Given this list of marker genes Apex1, Plac8, Stard3nl, Strap, Mybbp1a, Npm1, Tmem147, Ak2, Gnl3, Ppa1, Slc25a39, Ybx1 (Y box protein 1), Cdk2ap1, Uqcc4, Eif4a1 (NCBI Gene Id 13681), Cct3, Il4ra, Pdcd4, Lsm4, Eno1 (NCBI Gene Id 269605), Mettl1, Ppp3cc, Uqcc2, Hnrnpu, Elf1, Fabp5, Mia2, Eif5a, Hnrnpdl, Nolc1, Tpi1 (triosephosphate isomerase 1), Serbp1, Mif, Adh5, Trgc4, Farsa, Slc25a5 (NCBI Gene Id 11740), Dock10, Impact, Pa2g4, Wdr18 (NCBI Gene Id 76447), Hsp90ab1, Hmgb1, Mrps28, Chrac1, Supt16, Ydjc, Nme1, Mrpl36, Gzma, Denr, Snrpf, Nsun2, Lsm7, Nptn, Mrpl12, Tkt, Ptma, Fmc1, Nop56, Tsr3, Zfp593, Hprt1, Gadd45gip1, Cdk4, Taf10, Saysd1, Cd8a, F2r, Yaf2, Ndufaf8, Eif4ebp2, Shmt2, Med1, Gpatch4, Gnpnat1, Pum3, Npm3, Phgdh, Rtf2, Sec24b, Dkc1, Stat4, Glipr2, Cyfip2, Mrpl15, Socs1, Bcl2, Eif2s2, Uqcrq, Set, Ran, Dusp10, Ncl, Mthfd2, Cxcr6, Otulin, Trgc2, Cycs, Cdk6, Tcof1, Slc39a6, Ccdc115, Gstp1, Snu13, Srm, Inpp4b, Xbp1, Sec11c, Polr1g, Hectd1, Foxn3, Ranbp1, Gar1, Dctpp1, Agfg1, Trgv2, Ppp1r14b, Epop, H2-DMa, Slco3a1, Nop58, Ucp2, Cst7, Lyst, Tuba4a, Clcn3, Erh, Calr, C1qbp, here is a description of the gene set: from publication Cui A, Huang T, Li S, Ma A, Pérez JL, Sander C, Keskin DB, Wu CJ, Fraenkel E, Hacohen N (PMID 38057668) species: Mus musculus Cytokines mediate cell-cell communication in the immune system and represent important therapeutic targets. A myriad of studies have highlighted their central role in immune function, yet we lack a global view of the cellular responses of each immune cell type to each cytokine. To address this gap, the authors created the Immune Dictionary, a compendium of single-cell transcriptomic profiles of more than 17 immune cell types in response to each of 86 cytokines (>1,400 cytokine-cell type combinations) in mouse lymph nodes in vivo. A cytokine-centric view of the dictionary revealed that most cytokines induce highly cell-type-specific responses. For example, the inflammatory cytokine interleukin-1β induces distinct gene programmes in almost every cell type. A cell-type-centric view of the dictionary identified more than 66 cytokine-driven cellular polarization states across immune cell types, including previously uncharacterized states such as an interleukin-18-induced polyfunctional natural killer cell state. Mouse Gene Set: CUI_T_CELL_GD_IL4_RESPONSE_UP Genes positively differentially expressed in cell type: γδ T cell upon treatment with cytokine: IL-4 in mouse lymph nodes in vivo.